The following is a description of a gene set: studied in species Mus musculus from publication Cui A, Huang T, Li S, Ma A, Pérez JL, Sander C, Keskin DB, Wu CJ, Fraenkel E, Hacohen N (PMID 38057668) Mouse Gene Set: CUI_MAST_CELL_IL5_RESPONSE_UP Genes positively differentially expressed in cell type: Mast cell upon treatment with cytokine: IL-5 in mouse lymph nodes in vivo. Cytokines mediate cell-cell communication in the immune system and represent important therapeutic targets. A myriad of studies have highlighted their central role in immune function, yet we lack a global view of the cellular responses of each immune cell type to each cytokine. To address this gap, the authors created the Immune Dictionary, a compendium of single-cell transcriptomic profiles of more than 17 immune cell types in response to each of 86 cytokines (>1,400 cytokine-cell type combinations) in mouse lymph nodes in vivo. A cytokine-centric view of the dictionary revealed that most cytokines induce highly cell-type-specific responses. For example, the inflammatory cytokine interleukin-1β induces distinct gene programmes in almost every cell type. A cell-type-centric view of the dictionary identified more than 66 cytokine-driven cellular polarization states across immune cell types, including previously uncharacterized states such as an interleukin-18-induced polyfunctional natural killer cell state., and this is the list of marker genes: Map2k1, Armc5 (armadillo repeat containing 5), Cdr2, Snn, Slc44a2, Coq6, Klhl28, H2ax, Oas1a, Ift81